Given this list of marker genes SF3B5, NCBP2, SF3B6, SNRPG, POLR2A, POLR2D, ZMAT5, GTF2F2, POLR2C, SNRPD3, TXNL4A, POLR2H, PRPF8, SNRPD2, SRSF1, POLR2L, RNPC3, SF3B3, SNRNP200, SRSF2, SNRPE, DDX42, POLR2K, EFTUD2, DDX23, PDCD7, SNRNP40, GTF2F1, POLR2J, POLR2I, ZRSR2, SF3B4, PRPF6, POLR2G, POLR2B, SF3B1, SNRNP48, SNRPB, SF3B2, SNRNP25, SNRPD1, SNRNP35, SRSF7, NCBP1, POLR2E, SRSF6, POLR2F, SNRPF, ZCRB1, YBX1, here is a description of the gene set: Human Gene Set: REACTOME_MRNA_SPLICING_MINOR_PATHWAY species: Homo sapiens mRNA Splicing - Minor Pathway